Given this list of marker genes SLC35D2, AP5Z1, TCEA1, BMP5, CABLES1, CPEB2, ASPA, AP1S3, PYY2, SEC16B, ARHGAP6, NUDT16L1, LRRC47, ITGA2-AS1, DNAI3, DEDD, SNHG8, LINC01762, SPIN4, RAB13, GINS2, LINC03000, KIT, LAT, P2RX7, ETNK2, MPZ, TYRP1 (tyrosinase related protein 1), MARF1, SLC12A4 (solute carrier family 12 member 4), TESK1, TEX21P, RN7SL660P, FUZ, PAMR1, PPP2R5A, ANKRD33, ARID5B, HPSE2 (heparanase 2 (inactive)), MLANA, STK32A, C11orf96, SPRING1, PABIR1, CBLN1, ZNF665, CDNF, UNC119B, CRYL1, RAB38, FOXRED2, CDH19, COL24A1, BORCS7-ASMT, MME, SLC22A18, RPL17P9, SNHG1, SRRM2-AS1, DERL3, METTL9, TRPM6, PAX3, C12orf76, KCNAB2, COQ3, NAMA, PRKG2, GLMP (NCBI Gene Id 112770), DLGAP1-AS1, LINC00113, TEX41, MYO5A, VMA21, ZNF384, PNMA3, ABCB5, CECR3, here is a description of the gene set: Marker genes curated from the annotated cluster as represented in the Descartes Human Gene Expression During Development database. Human Gene Set: DESCARTES_FETAL_EYE_SMOOTH_MUSCLE_CELLS species: Homo sapiens from publication Cao J, O'Day DR, Pliner HA, Kingsley PD, Deng M, Daza RM, Zager MA, Aldinger KA, Blecher-Gonen R, Zhang F, Spielmann M, Palis J, Doherty D, Steemers FJ, Glass IA, Trapnell C, Shendure J (PMID 33184181) The gene expression program underlying the specification of human cell types is of fundamental interest. The study authors generated human cell atlases of gene expression and chromatin accessibility in fetal tissues. For gene expression, the study authors applied three-level combinatorial indexing to >110 samples representing 15 organs, ultimately profiling ~4 million single cells. The study authors leveraged the literature and other atlases to identify and annotate hundreds of cell types and subtypes, both within and across tissues. Our analyses focused on organ-specific specializations of broadly distributed cell types (such as blood, endothelial, and epithelial), sites of fetal erythropoiesis (which notably included the adrenal gland), and integration with mouse developmental atlases (such as conserved specification of blood cells). These data represent a rich resource for the exploration of in vivo human gene expression in diverse tissues and cell types.